Given this list of marker genes NCAM1, MED13, PHF10, UBE3A (ubiquitin protein ligase E3A), KIDINS220, SS18L1, KDM3B, PKNOX1, ZNF529, PGRMC2, NUDT4, CCDC82, VEZF1, NSD2, FAM8A1, HNRNPR, ZMIZ1, MARCHF6, DFFA, PAN2, TRIM13, ZNF273 (zinc finger protein 273), SAP130, RPL7L1, BSDC1 (NCBI Gene Id 55108), ZFAND3, GATC, EPM2AIP1, PARP6, SMAD5, PATZ1, PHF2, DCTN4, VPS26B, ZMYM2, COMMD9, ZFP14, FOXJ3, PHC1, C2CD5, KAT6B, ADNP, UBE2K, CEP170, MTMR3, TENT4A, NFYA, MFAP3, REPS1, RBM25, ZNF655 (zinc finger protein 655), EXOC5 (NCBI Gene Id 29024), EIF4ENIF1, ARID1A, PAIP1, USP37 (NCBI Gene Id 57695), SYNCRIP, FOXO3, USP33, CEBPG, PPM1D, SETD5, PRRC2B, MEX3C, RBM8A, REPIN1, ZNF384 (zinc finger protein 384), DYNC1I2, PAFAH1B2, ZNF84, IDH3G, POGZ, MED17, TMEM237, HIPK1, RABGEF1 (RAB guanine nucleotide exchange factor 1), KPNA3, CHTOP, ZSCAN21, LUC7L3, SYNC (syncoilin, intermediate filament protein), RBM4B, UBE2E3 (ubiquitin conjugating enzyme E2 E3), HSBP1, TADA1, BRD2, SCARB2, NAA25, LEMD3, KMT2E, TRAPPC6B, SPAG9 (sperm associated antigen 9), ELP1, FBXO30, TOMM70 (NCBI Gene Id 9868), IPO9, PTBP2, RALGAPA1 (Ral GTPase activating protein catalytic subunit alpha 1), ACSL3, CSRNP2, SPAST, ANKRD17, ISCA1, SNRNP200, DMTF1, KLHL11, ZFTA, DHX40 (DEAH-box helicase 40), DCAF7, NUP133, DHX36 (DEAH-box helicase 36), STRN4, ZFAND5, CELF1, PPIG, ZNF462, UBE2N, QSER1, FN3KRP, PRKRA, GTPBP1, CHD9, TARDBP, EPC2, ZBTB5, RMDN3, WBP11, HNRNPH3 (heterogeneous nuclear ribonucleoprotein H3), POM121C, UBR7, RABGAP1L, ARL6IP1, AHDC1, GTF3C4, JKAMP, FBRSL1, ILF3, HMG20A, LMNB1, PPM1E, SF3B4, USP22, AFG2B, CSDE1, CNOT7, PHACTR4, NGRN, KLHL42, BRPF3, NAB1, GSK3B, NCOA5, FAM168B, RABL2B, CAND1, IPO7, USP19, HECTD3, CRNKL1, ACBD6, SMC3 (NCBI Gene Id 9126), TNPO1, FBXO3, ZBTB33 (NCBI Gene Id 10009), RBFOX2, SLC25A29, CDIPT, ERG28, ARL5B, NAA30, KAT7, ZNF566, here is a description of the gene set: Neighborhood of MYST2 MYST histone acetyltransferase 2 in the GCM expression compendium species: Homo sapiens Neighborhood of MYST2 Human Gene Set: GCM_MYST2